The following is a description of a gene set: studied in species Homo sapiens Human Gene Set: GOBP_FUCOSE_CATABOLIC_PROCESS The chemical reactions and pathways resulting in the breakdown of fucose (6-deoxygalactose)., and this is the list of marker genes: HSD17B14, FUT6, FUT8, FUT4, FUT5, FUT9, FUT2, FUT10, FUT7, FUT1